The following is a description of a gene set: Human Gene Set: GOBP_AROMATIC_AMINO_ACID_FAMILY_CATABOLIC_PROCESS The chemical reactions and pathways resulting in the breakdown of aromatic amino acid family, amino acids with aromatic ring (phenylalanine, tyrosine, tryptophan). studied in species Homo sapiens, and this is the list of marker genes: TDO2, KYNU, CARNMT1, KMO, HAL, HPD, PAH, IL4I1 (interleukin 4 induced 1), IDO1, FAH, HDC, HGD, GSTZ1, AMDHD1 (NCBI Gene Id 144193), IDO2, AFMID, QDPR, ACMSD, UROC1, TAT, HAAO, CARNS1, HNMT, FTCD (formimidoyltransferase cyclodeaminase)